Given this list of marker genes FANCL, CARD8, FANCE, DOCK11, TNFAIP3, RAD51C, BRIP1, FANCF, PPP1R12A, TTC7A, MYCN, FGFR1, PALB2, PI4KA, FANCB, FANCG, FANCI, GPC4, XRCC2, GPC3, BRCA1, SMAD2, FANCC, RELA, RFX6, SLC9A3, ERCC4, UBE2T, RFWD3, GMPPB, DIS3L2, RBM8A, BRCA2, FANCD2, MAD2L2, FANCA, GTF2H5, XIAP, SLX4, RBM10, FOXF1, RAD51, MYH11, FANCM, here is a description of the gene set: Abnormal ileum morphology Human Gene Set: HP_ABNORMAL_ILEUM_MORPHOLOGY studied in species Homo sapiens